The following is a description of a gene set: A multiprotein complex containing a heterodimeric E2F transcription factor and a Retinoblastoma (Rb) family member. This complex is capable of repressing transcription of E2F-regulated genes in order to regulate cell cycle progression. studied in species Homo sapiens Human Gene Set: GOCC_RB_E2F_COMPLEX, and this is the list of marker genes: TFDP1, E2F2, CEBPA, RB1, E2F1